Given this list of marker genes Tnf, Ptgs2, Ccr5, Il1b, Ccl5, Ednrb, Cnr1, Ptger3, Ptges, Tnfrsf11a, Tnfsf11, here is a description of the gene set: Mouse Gene Set: GOBP_REGULATION_OF_FEVER_GENERATION Any process that modulates the rate or extent of fever generation. species: Mus musculus